Given this list of marker genes NSD1, PATZ1, H1-0, ANKRD11, THUMPD3, B4GALT5, DYRK2, NUMA1, PRICKLE1, TMEM177 (NCBI Gene Id 80775), RNF145, MXD3, DUS2, ASTE1, EHMT2, CLUAP1, PSRC1, PRDM15, NAV1, FRMD6-AS2, NFYA, CEP126, RPP25, ART4, here is a description of the gene set: Human Gene Set: GARGALOVIC_RESPONSE_TO_OXIDIZED_PHOSPHOLIPIDS_GREEN_DN Oxidized phospholipids are thought to promote atherogenesis by stimulating endothelial cells (ECs) to produce inflammatory cytokines, such as IL-8. In studies with mouse models, we previously demonstrated that genetic variation in inflammatory responses of endothelial cells to oxidized lipids contributes importantly to atherosclerosis susceptibility. We now show that similar variations occur in cultured aortic ECs derived from multiple heart transplant donors. These variations were stably maintained between passages and, thus, reflect either genetic or epigenetic regulatory differences. Expression array analysis of aortic EC cultures derived from 12 individuals revealed that >genes were regulated by oxidized phospholipids. We have used the observed variations in the sampled population to construct a gene coexpression network comprised of 15 modules of highly connected genes. We show that several identified modules are significantly enriched in genes for known pathways and confirm a module enriched for unfolded protein response (UPR) genes using siRNA and the UPR inducer tunicamycin. On the basis of the constructed network, we predicted that a gene of unknown function (MGC4504) present in the UPR module is a target for UPR transcriptional activator ATF4. Our data also indicate that IL-8 is present in the UPR module and is regulated, in part, by the UPR. We validate these by using siRNA. In conclusion, we show that interindividual variability can be used to group genes into pathways and predict gene-gene regulatory relationships, thus identifying targets potentially involved in susceptibility to common diseases such as atherosclerosis. Genes from the green module which are dn-regulated in HAEC cells (primary aortic endothelium) after exposure to the oxidized 1-palmitoyl-2-arachidonyl-sn-3-glycerophosphorylcholine (oxPAPC). from publication Gargalovic PS, Imura M, Zhang B, Gharavi NM, Clark MJ, Pagnon J, Yang WP, He A, Truong A, Patel S, Nelson SF, Horvath S, Berliner JA, Kirchgessner TG, Lusis AJ (PMID 16912112) studied in species Homo sapiens